Given this list of marker genes TDO2, KYAT1, AADAT, KYAT3, SLC7A5, KYNU, SLC36A4, IDO2, KMO, SLC3A2, ACMSD, HAAO, IDO1, AFMID, here is a description of the gene set: species: Homo sapiens part of: Metabolism of amino acids and derivatives Reactome Pathway: Tryptophan catabolism Tryptophan is catabolized in seven steps to yield aminomuconate. Intermediates in this process are also used in the synthesis of serotonin and kynurenine.